Given this list of marker genes Ly6a, Tmsb10, Gab1, Tgtp2 (NCBI Gene Id 100039796), Tmem229b, Emp1, Evl, Desi1, Eid1, Gm2a, Gimap4, Alpl, Slc66a3, Xrcc6, Cyfip2, Cd74, Gbp2, Slfn2, Blk, Serinc3, H2-T10, Myo7a, here is a description of the gene set: studied in species Mus musculus Genes down-regulated in pre-B lymphocytes upon Cre-Lox knockout of E2A. Mouse Gene Set: GREENBAUM_E2A_TARGETS_DN from publication Greenbaum S, Lazorchak AS, Zhuang Y (PMID 15310760) The transcription factors encoded by the E2A gene have been shown to play essential roles in the initiation and progression of lymphocyte development. However, there is still a lack of comprehensive understanding of E2A downstream genes in B-cell development. We previously developed a gene tagging-based chromatin immunoprecipitation (ChIP) system to directly evaluate E2A target genes in B-cell development. Here, we have improved this ChIP strategy and used it in conjunction with microarray analysis on E2A-deficient pre-B-cell lines to determine E2A target genes in lymphocyte development. Both microarray data and ChIP studies confirmed that E2A directly controls IgH gene expression. The microarray assay also revealed genes that were significantly up-regulated after E2A disruption. ChIP analysis showed that E2A was most likely to be directly involved in repression of some of these target genes such as Nfil3 and FGFR2. An inducible E2A reconstitution system further demonstrated that E2A-mediated repression of Nfil3 and FGFR2 was reversible. Collectively, these findings indicate that E2A is a positive regulator for one set of genes and a negative regulator for another set of genes in developing B lymphocytes.